The following is a description of a gene set: Human Gene Set: MIR10392_3P species: Homo sapiens Genes predicted to be targets of miRBase v22 microRNA hsa-miR-10392-3p in miRDB v6.0 with MirTarget v4 prediction scores > 80 (high confidence targets). from publication Chen Y, Wang X (PMID 31504780), and this is the list of marker genes: PTPN14, IRAK1, LTB, CISH, GRAMD1A, SYN2